The following is a description of a gene set: A type of blepharitis that affects the meibomian glands and meibomian gland orifices. This abnormality can be associated with a spectrum of appearances ranging from meibomian seborrhoea (foaming meibomian gland secretions) and meibomianitis (inflamed meibomian glands), to chalazia. Human Gene Set: HP_POSTERIOR_BLEPHARITIS studied in species Homo sapiens Posterior blepharitis, and this is the list of marker genes: GJB2, UROD, GJB6, SREBF1, UROS, GATA1, MBTPS2